The following is a description of a gene set: Lymphangioma Lymphangiomas are rare congenital malformations consisting of focal proliferations of well-differentiated lymphatic tissue in multi cystic or sponge like structures. Lymphangioma is usually asymptomatic due to its soft consistency but compression of adjacent structures can be seen due to the mass effect of a large tumor. species: Homo sapiens Human Gene Set: HP_LYMPHANGIOMA, and this is the list of marker genes: CCBE1, AKT1, COL18A1, PTH1R, FAT4, IDH2, PTEN, ADAMTS3, PIK3CA, PAK2, IDH1